Given this list of marker genes BAIAP2L1, ECPAS, CBLL1, LRWD1, DCUN1D4, TAX1BP3, SCAF11, SMPD4, MED13L, UROD, FOXP1, TMEM242, NUDT4, EXOC2, EHD3, XRCC1, CDKN2D, DBF4, CMAS, DHFR, GRPEL2, CYSLTR1, SDHB, LATS1, SLX4, SKA3, NUF2, PPP2R5C, UBE2H, ERI2, KIFC1, CDK1, FIG4, KIF18B, CUL2, SEC23IP, HNRNPA1, FAAP24, ANXA2 (annexin A2), MIS18BP1, PFN2, PSMC3, RASSF6, CPSF2, FRMD4B, DNAJC12, GRK2, NFYB, HPSE, DHX40, DDX46 (DEAD-box helicase 46), SMARCC1, PHOSPHO2, POLH, TRIM37, MBD4 (methyl-CpG binding domain 4, DNA glycosylase), SLC25A51, CKAP2L, BCKDHA, UAP1, BTK, HMGCL, MSL3, HP1BP3, SPC24, CTDSP2, PYROXD1, ABCD3, C1GALT1, ACBD3, ZNF518B, PRR11, TIFA, USO1, TFDP2, MBNL3, AGO4, CMPK1, FH, AKR1B1, WASHC4, BRWD1, KIAA1191, SUV39H1, KIF11, LMO4, CTCF, CCNG2, NGLY1, RET, B9D1, CPM, RTCB, TMEM131L, PCYOX1, SLC25A33, GKAP1, ITGA6, KRT222, USP47, NSMCE4A, RDM1, LBR (NCBI Gene Id 653311), TUBD1, ASXL1, YPEL3, PCK2, MND1, LNX2, PMPCA, AKAP12, BCL2L11, MYBL1, SLC30A5, FAM117A, MAN2C1 (mannosidase alpha class 2C member 1), THOC3, VPS45, NDC80, CCP110, ARL6IP1, AKT1, MAN2A1, ACSS1, MSH2 (NCBI Gene Id 8169), SERPINF1, PRPS2, NCAPG, CHFR, ARHGAP29, MKI67, PLCG1, H2AZ1, POLR2G, C2CD5, SMARCA4, IFT46, GOPC, RNF125, SASS6, APPBP2 (amyloid beta precursor protein binding protein 2), BNIP2, KIF23, G2E3, BRD8, SGO1, HMGN5, AP1AR, BCL7A (NCBI Gene Id 605), COQ2, GPSM2, SPATA24, CDCA8, CDC7, TERF2, CCNF, SLFN13, ANKFY1 (NCBI Gene Id 57500), TERF2IP, MSH3, DNAI4 (dynein axonemal intermediate chain 4), NATD1, FNTA, BLVRB, SLC66A2, IFIT1, RPIA, KCTD9, NUP107, NCAPH, HELQ, CXCR4, ANAPC7 (NCBI Gene Id 51434), SORD (sorbitol dehydrogenase), KLHDC4, TRPC4AP, DGKD, IDH2, POLI, PSMD12, PDE4B, OGFRL1, RALBP1, ZNF821, REEP4, PLEKHA2, PNP, ESPL1 (NCBI Gene Id 9700), INPP5B, NFATC3, SGO2, SUMO3, VIRMA, H1-10, KCNN4, CMC2, OGA, NADK2, NEIL1, PIF1, here is a description of the gene set: Human Gene Set: GSE37532_TREG_VS_TCONV_PPARG_KO_CD4_TCELL_FROM_LN_UP from publication Cipolletta D, Feuerer M, Li A, Kamei N, Lee J, Shoelson SE, Benoist C, Mathis D (PMID 22722857) studied in species Homo sapiens We identified Pparg as a major orchestrator of the phenotype of adipose-tissue resident regulatory T cells (VAT Tregs). To establish the role of Pparg in shaping the VAT Tregs gene profile and cell dynamics, Tregs from lymph nodes and visceral adipose tissue of mice sufficient and deficient of Pparg expression in Tregs were double sorted for microarray analysis. Genes up-regulated in lymph node from aged PPARG knockout mice: T reg versus T conv.